Given this list of marker genes ERBB4, STAP2, RHOA, CDK4, BTC, EGFR, PELP1, KHDRBS1, NR3C1, NRG1, SFPQ, EGF, CRK, ELMO2, UBA52, CBL, ARAP1, BCAR1, HBEGF, AKT1, DOK1, DOCK1, RASA1, LRRK2, EREG, CCND1, UBB, GPNMB, ELMO1, KHDRBS3, NRG2, PTK6, NRG4, UBC, SRMS, KHDRBS2, ERBB3, SOCS3, NRAS, ARHGAP35, HRAS, NRG3, PXN, ERBB2, CDKN1B, CDK2, STAT3, PTPN1, RPS27A, HIF1A, EPAS1, CCNE1, KRAS, RAC1, here is a description of the gene set: Signaling by PTK6 Human Gene Set: REACTOME_SIGNALING_BY_PTK6 studied in species Homo sapiens